The following is a description of a gene set: Human Gene Set: SCHERER_PBMC_APSV_WETVAX_AGE_18_32YO_2_TO_4DY_UP from publication Scherer CA, Magness CL, Steiger KV, Poitinger ND, Caputo CM, Miner DG, Winokur PL, Klinzman D, McKee J, Pilar C, Ward PA, Gillham MH, Haulman NJ, Stapleton JT, Iadonato SP (PMID 17651872) studied in species Homo sapiens Genes up-regulated in peripheral blood mononuclear cell (2 to 4)d vs 0d in adults (18-32) after exposure to APSV Wetvax, time point 2 to 4D Gene expression in human peripheral blood mononuclear cells was systematically evaluated following smallpox and yellow fever vaccination, and naturally occurring upper respiratory infection (URI). All three infections were characterized by the induction of many interferon stimulated genes, as well as enhanced expression of genes involved in proteolysis and antigen presentation. Vaccinia infection was also characterized by a distinct expression signature composed of up-regulation of monocyte response genes, with repression of genes expressed by B and T-cells. In contrast, the yellow fever host response was characterized by a suppression of ribosomal and translation factors, distinguishing this infection from vaccinia and URI. No significant URI-specific signature was observed, perhaps reflecting greater heterogeneity in the study population and etiological agents. Taken together, these data suggest that specific host gene expression signatures may be identified that distinguish one or a small number of virus agents., and this is the list of marker genes: CXCL10, CD63, MXD1, VNN2, GBP2, LIMK2, BCL2A1, IFIT1, DYSF, WARS1, CEACAM1, ATF3, ANKRD22, IFIT3, FCGR1A, HERC5, SERPING1, NFIL3, PFKFB3, ANXA3, HBB, CXCR1, IRF1 (NCBI Gene Id 96501), ATG2A, NAMPT, IFI44L, MX1, FGL2, SOCS3, PTPRJ, IGF2R, ICAM1, FCGR3A, ADM, IFI44, HMCES, GAB2, TBXT, AQP9, SLC12A7, IL15, DNM1, FCGR2B, OR2V2 (olfactory receptor family 2 subfamily V member 2), IER3, SLC35A2, LAP3, HLX, GCH1, CLSTN3, DSC2, STAT1, FPR1, RSAD2, ZNFX1, MCL1, C2, SOD2, KCNJ15, HBD, CEBPB, UBE2L6, BCL6